The following is a description of a gene set: studied in species Homo sapiens Nocturia Abnormally increased production of urine during the night leading to an unusually frequent need to urinate. Human Gene Set: HP_NOCTURIA, and this is the list of marker genes: TWNK, CTSH, MOG, TNFSF4, CLCNKB, SLC25A4, ZNF365, POLG2, RRM2B, HLA-DRB1, DBH, HCRT, SLC12A3, P2RY11, POLG, PLA2G6, HLA-DQB1